The following is a description of a gene set: species: Mus musculus Catalysis of the reaction: L-lysyl36- + 3 S-adenosyl-L-methionine = 3 H+ + N6,N6,N6-trimethyl-L-lysyl36- + 3 S-adenosyl-L-homocysteine. This reaction is the successive addition of three methyl groups to the lysine residue at position 36 of histone H3, producing histone H3K36me3. Mouse Gene Set: GOMF_HISTONE_H3K36_TRIMETHYLTRANSFERASE_ACTIVITY, and this is the list of marker genes: Setd2, Prdm9, Ash1l, Nsd2 (NCBI Gene Id 77281), Smyd5